Given this list of marker genes Slc28a3, Slc29a3, Slc29a2, Slc29a1, Slc28a2 (solute carrier family 28 (sodium-coupled nucleoside transporter), member 2), Slc29a4, Slc25a26, Slc28a2b, Slc28a1, here is a description of the gene set: The directed movement of nucleoside across a membrane. species: Mus musculus Mouse Gene Set: GOBP_NUCLEOSIDE_TRANSMEMBRANE_TRANSPORT